The following is a description of a gene set: studied in species Homo sapiens Replacement of bone marrow by fibrous tissue. Human Gene Set: HP_MYELOFIBROSIS Myelofibrosis, and this is the list of marker genes: SRC, TLR8, TET2, SH2B3, JAK2, CALR, MPL, SHOC2, TBXAS1, NBEAL2, MPIG6B, GFI1B, TP53